Given this list of marker genes Polr2a, Uvssa, Polr2e, Ubb, Ercc6, Polr2k, Ddb1, Ercc2 (NCBI Gene Id 13871), Gtf2h4, Xpa, Xab2, Ercc3, Cul4a, Polr2f, Polr2i, Polr2l, Cul4b, Rps27a, Ccnh, Polr2c, Polr2b, Cops6, Prpf19, Zfp830, Tcea1, Gtf2h2, here is a description of the gene set: electronically inferred by orthology from the curated human pathway Reactome Pathway: Formation of TC-NER Pre-Incision Complex This event has been computationally inferred from an event that has been demonstrated in another species.<p>The inference is based on the homology mapping from PANTHER. Briefly, reactions for which all involved PhysicalEntities (in input, output and catalyst) have a mapped orthologue/paralogue (for complexes at least 75% of components must have a mapping) are inferred to the other species. species: Mus musculus part of: Transcription-Coupled Nucleotide Excision Repair (TC-NER)